The following is a description of a gene set: Mouse Gene Set: FOXJ2_TARGET_GENES from publication Yevshin I, Sharipov R, Kolmykov S, Kondrakhin Y, Kolpakov F (PMID 30445619) Genes containing one or more binding sites for (Foxj2) in their promoter regions (TSS -1000,+100 bp) as identified by GTRD version 20.06 ChIP-seq harmonization. studied in species Mus musculus, and this is the list of marker genes: Dusp18 (NCBI Gene Id 75219), Defb44-ps, Dnajc7, Plec, Hycc2, Tmco1, Mir130c (NCBI Gene Id 102466640), Rbck1, B4galt7, Arhgef10l, Zfp523, Ndufb3, Lig4, Zfp276, Cfap20, Ncbp1, Ovol2, Gm13049, Acad11, Helq, F2rl1, Ighmbp2 (NCBI Gene Id 20589), Pold3, Wdr77, Mrps34, Pygo2, Ints14, Mir6359, Mtor, Zer1, Cpsf3, Zfp667, Ipo8, 1700003D09Rik, Mrpl44, Zbtb7b, Mrps27, Mrpl3, Tbc1d19, A430105J06Rik, Ptrh2, Snrpd3, Sec24a, Pgd, Gm28535, Cwc22, 2700062C07Rik, Pih1d2, Cdc16, Atp6v1g2, Cd2bp2, Pus10, Gm6288, Ccz1, Mettl5os, Dcaf10, Rps7, Neu3, Ttc4, Eif3f, Eloa, Mettl26, Rab15, Nudt5 (NCBI Gene Id 53893), Elp2, Dph1, Acsf3, Appl2 (NCBI Gene Id 216190), Hdc, Sf3a3, Naxe, Mcee, Nvl, Atp8b1, Homer1, Cdk12 (NCBI Gene Id 69131), Trim25, Vps25, Aldh3b2, Fbxo22, Actn4, H4c14, Vwa8, Mrpl1, Mrpl30, Slc33a1, Por, Cops7b, Mkrn3, Ptpa, Norad, Malat1, Map2k5, Rtel1, Cops2, Ptcd2, Zfp579, Rrp15, Exoc2, Nek4, Osbpl1a, Actl6a, Tbrg1, Slc39a3, Gtse1, Zmpste24, 8430429K09Rik, Gtf3c3 (general transcription factor IIIC, polypeptide 3), Bloc1s6os, Tppp3, Eif4e2, Cep104, Tefm, Ccdc142os, Dpp9, Ddx56, 4930558K02Rik, Bcl10, Lzic, Gm24905, Agbl5, Golga3, Trub2, Wars1, Jade1, Nr1h3, Dhx38, Dffb, Tbc1d13, Dnajb6, Acbd6, Mettl15, Cwc27, Efcab7, Las1l (NCBI Gene Id 76130), Prrg2, Ncbp2, Myo10 (NCBI Gene Id 52514), Cnih4, Tbc1d7, Cacng3, Spout1, Psmd2, Zbtb11, Dus1l, Mettl23, Airn, Cdc123, Raf1, Ino80b, Nkap, Taco1, Atpaf1, Ptpn21, Bms1, Wdfy1, Mageb16, Mtg1, Bloc1s6, Ddx18, Tsen54, Slc44a1, Them4, Myadm, Klhdc2, Ccn2, Agtpbp1, Tap1, Ect2, Ndufs7, Gtf3c5, Itgb3bp, Ncbp2as2, Wdr24, Mir6961, Ndufa12, Mrpl13, 1110038F14Rik, Arfgap3, Smg7, Gm4610, Mterf4, Prom2, Tmem68, Tex2, Wsb2, Cluap1, Sri, Sar1b, Ndufc2, Zfp668, Fgd3 (NCBI Gene Id 76091), Serhl, Rpl18, Fbxw8, Nol12, Isy1, Eef2k, Dnajc24, Dnajc2, Kctd5, Ublcp1, Gm13830, Psph, Dhrs7b, Gucd1, Ano6, Txnl4b, Eif3i (eukaryotic translation initiation factor 3, subunit I), Ddost, Ndufs1 (NADH:ubiquinone oxidoreductase core subunit S1), Mrpl21, 2610005L07Rik, Wdr11, Srp19, Yipf2, Tgs1, Rpl29, Psmg1, Rgl2, Bbs1, Usp30, Ap3s2 (NCBI Gene Id 11778), Sphk2, Pcid2, 4933434E20Rik, Tada3, Sec22b (NCBI Gene Id 99656), Fam8a1, Tor1aip2, Gtf2h2, Dctn5, Yju2, Nsl1, Arhgap9, Aqr, Dpy19l4, Tmem54, Vps9d1 (NCBI Gene Id 72325), Fam149b, Mir203, Gstcd, Vpreb1a, Ndufaf1, Gin1, 4930510E17Rik, Dynll1, Ppp1r11, Cul4a, Nosip, Slc44a2, Mm2pr, Ecd, Nelfb, Snrnp27, Il17re, Gm20257, Trip4, Rps19bp1, Cnpy3 (NCBI Gene Id 73685), Anapc5, Psmc1, Chchd2, Mettl9, Polr1b, Sharpin, Mrpl16, Gm24735, Alg3, Dysf (NCBI Gene Id 26903), 1810021B22Rik, Rpl22, Pdzk1ip1, Srek1ip1, Abhd4, Zfp646, Pabpc4, Med17, Hus1, Uba5, Smim8, Nkapd1, Exosc4, Trdmt1, Tbc1d15, Atp5pb, Ndufs3 (NCBI Gene Id 68349), Mphosph10, Gemin7, Nek9, Tsnax, Stx16, Vps52, 1700037C18Rik, Kbtbd4, Cald1, Ccnc, Vps51, Dnaaf9 (NCBI Gene Id 98941), Arl6ip4, Mpzl3, Usp36, Pex3, Ly6g6c, Utp3 (NCBI Gene Id 97272), Mrpl20, Cox7a2, Qrich1, Aar2 (NCBI Gene Id 68295), Stx18, Uspl1, Tmem234, Trmu, Opa1, Otud7b (OTU domain containing 7B), Psmc2, Trp53rka, Ercc1, Eefsec, Srsf11, Wdr70, Ints5, Tmem242, Zcchc4, Sucla2, Rab23, Gm26782, Lrrc49, Gm5129, Gm15564, Ddx55, Rnf225, Kbtbd7, Fem1b, Fibp, Slc4a1ap, Gm30238, Nploc4, Spef1, Nbeal1, Klhdc4, Gm15787, Cblc, Chordc1, Nup54, Esrp2, Palb2, Slc39a13, Coq4, Hira (histone cell cycle regulator), Ccdc107, Rimoc1, Fra10ac1, Aurkaip1, Tatdn3, Cltc, Jmjd6, Il2rb, Nsfl1c, Zfp606, Or13p4 (NCBI Gene Id 258708), Taf1b, Fam118a, Zfp770, Mtmr9, Trabd, Top3b, Slc15a4, Cdk5rap1, Mrpl39, Mitd1, Tufm, Bst1, Gm26513, Ssbp1, Epn3, Cops4, Cbl, Epcam, Nkiras2 (NCBI Gene Id 75157), Ube2j2, 5430416N02Rik, Tmem101, Ano8, Arhgap1, Clpb, Lasp1, Vti1a, Klhl20, Plekhm3, Cpsf1, Necap2, Krr1, Gm13783, Ctu1, Gm11515, Pigc, Rps18, Ankrd40, Cuedc1, Tut1, Adam17, Ptpn14, Tsen15, Mnat1, Ankrd13c, Kmt2a (NCBI Gene Id 214162), Vps72, Tor1aip1, Nop16, Rbbp8nl (RBBP8 N-terminal like), Birc6, Mrps31, Nfkbil1, Tars2, Prmt5, Sugct, Hemk1, Eef1b2, Cfap298 (cilia and flagella associate protien 298), Mplkip, Bnip2, Tmem115, Chchd5 (NCBI Gene Id 99288), Ubac2, Frmd4b, Pcnx3, Mrps15 (NCBI Gene Id 72204), Syt8, 6030442K20Rik, 1700125G22Rik, Ubiad1, Arhgap32, Spaca6, 1110008E08Rik, Egfl7, Ppil3, Drg2, Supt7l, Lrrc59, Abhd13, Itgb1bp1, Mrps18c, Nmnat1, Etfbkmt, Faf1 (Fas-associated factor 1), Gm3716, Pigq, Ube2g2, Dpp8, 2310057M21Rik, Wdr36, Gm2093, Naa35, H4c16, Hat1, Etl4, Tjp2, Eme2, Mtbp, Hsp90aa1, Rnf185 (ring finger protein 185), Zswim1, Ccdc57, Pex13, Katnal1, Glrx, Dnttip2, Med23, Agk, Cldn4, Edc4, Senp1, Dcdc5, Man2c1, Champ1, Psmf1, Mir6236, 1810041H14Rik, Commd2, H6pd, Mrpl40, Cpsf4l, Smg8, Gtf2h4, Zfp408, Ccar2, Chmp4b, Radil, Tfeb, Amotl2, Maf1, Gpatch8, Exd2, Tmem69, Nsa2, Strip1, Gm5447, Ppfibp1, Cct6a, Dcp1a, Tnpo3, Rad54l2, Banp, Tma16, Mtif2, Trpm4, Rpl37, Cacybp, Gm9358, Nif3l1, Tmem267, 4921536K21Rik, H4c6 (NCBI Gene Id 319157), Ndufaf7 (NADH:ubiquinone oxidoreductase complex assembly factor 7), Zfp114, Gfm2, Ilf2, Mcm3ap, Gtpbp3 (NCBI Gene Id 70359), Creb5, Hipk1, Hspa5, Odad4, Tmem222, Zfp322a, Hmgb1, Srrt, Sec13, Arpc4, Stoml2, St7, Mettl5, Slc39a6, Timmdc1, Mir7b, Nuf2, Pramel13os, 2610203C22Rik, Mlec, Nme1, Dhodh, H4c3, Mrpl53, Sdhaf3, Rbm34, Polr3e, Mrpl48 (mitochondrial ribosomal protein L48), Cyb5r4, Fam219b, Aaas, Tln1, Ppan, Usp8, Mdfic, Fam227b, Cyth2, 5430400D12Rik, Zfp11, Ece2, Bag6, 6820431F20Rik, Tbp, Zbtb45, Vamp4, 3110070M22Rik, Slc35a3, Tstd2, Vmp1, Sec31a, Ift56, Wdr25, Polr3b, Tdrd7, Rbbp5, Zdhhc6, Ddx1, Mrpl58, Dmap1, Gtpbp4 (GTP binding protein 4), Ap1g1, Psmg3, Cnot10, Sirt4, Trp53rkb, 5730455P16Rik, Antkmt, Dhx33, Zkscan8, Mkrn2, Acp2 (acid phosphatase 2, lysosomal), 1810019D21Rik, Wbscr25, Fam98b, Tmem41b, Cebpz, Pemt, Galk2, Lsg1, Pdss1 (NCBI Gene Id 80460), Vps45, Eif4a2, Dtwd1, Dad1, Ints12